Given this list of marker genes Sat1, here is a description of the gene set: part of: Metabolism of polyamines Reactome Pathway: Interconversion of polyamines species: Mus musculus This event has been computationally inferred from an event that has been demonstrated in another species.<p>The inference is based on the homology mapping from PANTHER. Briefly, reactions for which all involved PhysicalEntities (in input, output and catalyst) have a mapped orthologue/paralogue (for complexes at least 75% of components must have a mapping) are inferred to the other species. electronically inferred by orthology from the curated human pathway